The following is a description of a gene set: studied in species Mus musculus A protein complex that stimulates the exchange of guanyl nucleotides associated with a GTPase. Mouse Gene Set: GOCC_GUANYL_NUCLEOTIDE_EXCHANGE_FACTOR_COMPLEX, and this is the list of marker genes: Lamtor2, Rap1a, Mon1b, Rgp1, Rasgrp3, Eif2b2, Mon1a, Lamtor5, Lamtor1, Eif2b4, Lamtor3 (NCBI Gene Id 99927), Eif2b5, Ric1, Slc38a9, Smcr8, Ccz1 (CCZ1 vacuolar protein trafficking and biogenesis associated), Lamtor4, Pde3b, Eif2b3 (eukaryotic translation initiation factor 2B, subunit 3), Kndc1, Wdr41, Eif2b1, Rmc1 (regulator of MON1-CCZ1), Dgki, C9orf72, Dock1, Elmo1